The following is a description of a gene set: Mouse Gene Set: MIR_224_5P species: Mus musculus from publication Chen Y, Wang X (PMID 31504780) Genes predicted to be targets of miRBase v22 microRNA mmu_miR_224_5p in miRDB v6.0 with MirTarget v4 prediction scores > 80 (high confidence targets)., and this is the list of marker genes: Rtl4, Rer1, Zdhhc20, Acin1, Rnf38, Dsg1b, Crebrf, Diaph2, Pou3f2, Pikfyve, Ttc3 (NCBI Gene Id 70444), Cts7 (NCBI Gene Id 56092), Ubqln2, Reln, E2f3, Kcnrg, Kdm3a, Plekhd1, Neto2, Prpf4b, Atp12a, H3f3b, Wasf1, Acsl4, Cdk19, Akirin1, Rfk (NCBI Gene Id 67438), Ak1, Igf2r, Npr1, Hipk3, Gmps, Slc5a7, Klrb1f, 2310022A10Rik, Slc9a2, Ttc9, Kctd11, Ptx3, Tmprss12, Ggact, Ptprb, Kat6a, Wtap, Ttc19, Krtap6-3 (NCBI Gene Id 100093623), Dennd5b, Notum, Pate6, F2r, Cnga4, Mkrn2, Ggnbp2, Slc4a4, Egr2, Trim52, Tmem117, Kansl3, Slc38a6 (solute carrier family 38, member 6), Znhit6, Cyb561a3, Cstf2, Gpc4, Ube2d3, Cd53, Dock3, Fryl, Exo1, Prss35, Enah, Asph, Pnn, Ism1, Lats2, Fhl2, Thap1, Kif17, Zbtb14, Myt1l, Plet1, Hnrnpu, Alkbh1, Map4, Zfp2, Maf1, Myh11, Tank, Nwd2, Cxadr, 9230112D13Rik, Fem1b, Asb1, Tmem9b (TMEM9 domain family, member B), Zfp207, Arf6, Dach2, Samd8, Atf2, Trim9, Tceanc, Abhd3, Otub2, Pvr, Vps35, Rab10, Hoxd10, Pdcl2, Rab27b, Rmdn3, Rabepk, Adam22, Zfp738, Ptprm, Dnm1, Slc8a1, Dync2i1, Prelid3b, Srl, Sppl3, Ric1, Psmc6, Idh1, Cpne8, Palld, Nfs1, Rassf8, Rbm46, Smad4 (NCBI Gene Id 28063), Nap1l5, Mbnl2, Psap, Irx2, Pik3c2a, Kif23, Pdgfra, Hebp1, Zfp423, Rasa2, Plpp3, Zfp174